The following is a description of a gene set: Genes predicted to be targets of miRBase v22 microRNA mmu_miR_7087_5p in miRDB v6.0 with MirTarget v4 prediction scores > 80 (high confidence targets). Mouse Gene Set: MIR_7087_5P species: Mus musculus from publication Chen Y, Wang X (PMID 31504780), and this is the list of marker genes: Cdk16, Ptpn12, Pik3r2, Zfp704 (NCBI Gene Id 269407), Tln1, Myo1d, Adamts1, Mindy2, Asic2, Atg4b, Esrrg, Castor2, Slc24a2, Dgkk, Otub1, Tgfbr3, Kcnh1, Atxn1, Tnip1 (NCBI Gene Id 57783), Hunk, Gid4, Dpp8, Armc9, Fundc2, Hccs, Glis1, Birc6, Plxna1, Dynap, Plec, Slc30a3, Abcb9, Phf24, Mdga1, Crat, Tbc1d25, Pcdh17, Mpp1, Itga8, Lrit1, Paip1, Kcns1, Cdh8, Smarce1, Eef1a1, Tmem231, Slc6a17, Cd1d1, Zfp354b, Rhobtb1, Rubcn, Nckap1 (NCK-associated protein 1), Wipf2, Ndrg1, Nfe2l1, Naa30, Klhl25, Kdm6a, Dennd5a, Cap1, Tatdn1, 6430548M08Rik, Trio, Inpp4a, Pdxdc1, Aoc1, Zfp608, Sh2b3, Foxo3, Rnf185, Ppargc1a, Rundc3a, Ephb2, Prdx1, Igf1r, Ube2m, Ppp2r3a, Ppp1r1b, Ddx3x, Acox3, Mak (NCBI Gene Id 17152), Map1b